The following is a description of a gene set: studied in species Mus musculus Mouse Gene Set: GOBP_NEGATIVE_REGULATION_OF_CGAS_STING_SIGNALING_PATHWAY Any process that stops, prevents or reduces the frequency, rate or extent of cGAS/STING signaling pathway., and this is the list of marker genes: Banf1, Irgm2, Prkdc, Igtp, Ppp6c, Aars2, Akt1, Lyplal1, Smpdl3a, Trex1, Pcbp2, Zdhhc18, Cgas, Parp1, Aurkb, Irgm1, Spsb3